The following is a description of a gene set: Human Gene Set: GOBP_REGULATION_OF_T_HELPER_1_CELL_DIFFERENTIATION species: Homo sapiens Any process that modulates the frequency, rate or extent of T-helper 1 cell differentiation., and this is the list of marker genes: ANXA1, HLX, IL27 (interleukin 27), ASCL2, SOCS5 (suppressor of cytokine signaling 5), JAK3, RIPK2, TNFSF4, IL4R, CD80, CCL19